The following is a description of a gene set: studied in species Mus musculus part of: alpha-linolenic (omega3) and linoleic (omega6) acid metabolism electronically inferred by orthology from the curated human pathway This event has been computationally inferred from an event that has been demonstrated in another species.<p>The inference is based on the homology mapping from PANTHER. Briefly, reactions for which all involved PhysicalEntities (in input, output and catalyst) have a mapped orthologue/paralogue (for complexes at least 75% of components must have a mapping) are inferred to the other species. Reactome Pathway: alpha-linolenic acid (ALA) metabolism, and this is the list of marker genes: Acaa1b, Elovl5, Elovl3, Hsd17b4, Elovl2, Acot8, Abcd1